Given this list of marker genes SYT2 (NCBI Gene Id 6858), MECOM, CEP57, NELFA, RPS26, TTC7A, FRAS1, MYOD1, RPS17, NDN, MAP3K20, ADA, DNA2, EPB41, GTF2IRD1, MT-ND1, MAX, EIF4H, CNTNAP1, PIGL, TBCK, SZT2, NPC1, TREM2, PLPBP, TRIP13, KIF26A, TIMMDC1, TLK2, PTH1R, EXTL3, DPF2, UNC45B, TCF4 (transcription factor 4), SCN4A, KLHL40, GABRG2, TRIP11, BMPER, YWHAG, SON, SMN1, B3GLCT, PEX2, CYFIP2 (cytoplasmic FMR1 interacting protein 2), MYH3, GTF2I, GAA, ATP1A3, PIGA, RIPK4, DHDDS, SOS2, RPS24, KRAS, ABCB4, CACNA2D1 (NCBI Gene Id 781), HBA2, TAF6, FLT4, RPL31, VCP (NCBI Gene Id 94731), SMC1A, PIGY (NCBI Gene Id 84992), MRAS, CASP10, BSND, MAPT, LZTR1, RFC2, H19, EFNB1, NAA10, NDUFB9, HOXD13, RAI1, CARS2, MDFIC, TRPV4, HLCS, ATP6V1B2, PEX26, FOXC2, KBTBD13, PARS2, UQCRFS1, SCYL2, GATA1, GNB2, VPS35L, PAX7, SLC25A26, PLD1, MEGF10, MTM1, KCNC2, ZSWIM6, NCF1, RAD21, NFASC, RRAS2, PRUNE1, PWAR1, GOSR2, DPYSL5, FAT4, COL6A1, RPL26, CAMK2B, RPS29, CLPB, RYR1, CRB2, NEK9, ARSL, SPTA1, SLC5A7, RRAS, SLC17A5, NDUFAF5, SLC2A1, SCN5A, DHPS, CRPPA, NDUFAF2, TMCO1, BUB1B, GATB, DEAF1, ITPR1, NDUFAF1, FLG, NTRK2, SCN3A, PIGV, KCNQ5, SPRED2, KMT2D, PAK2, NDUFV2, HCN1, NDUFS2, HACD1, MMACHC, PTRH2, LAMA5, DNM2, DNMT3A, PGAP2, NDUFS7, CNTN1, NEU1, NSD2, FANCF, IL7R, LBR, RHD, KANSL1, SLC3A1, ATN1 (atrophin 1), ATP8B1, NDUFV1 (NCBI Gene Id 4723), MRPS16, GUSB, SLC26A2, FZR1, EBF3, HEATR3 (HEAT repeat containing 3), TMEM270, PMM2, LIMK1, RAPSN, FASLG, DOHH, LGI4, GRIP1, RET, POLR2A, ZNF699, NDUFA10, SLC13A5, PGAP3, MRPS22, KLF1, ADGRG6, STX1A, DMPK, NPC2, MCM10, ASCL1, RPS10, MYT1L, CLIP2, SYNJ1, GABBR2, RPL15, BAZ1B, RASA1, FXR1, PLOD1, PREPL, GBE1, RPS19, SNUPN, MAGEL2, VAMP1, FGFR3, CHAT, CDAN1, CPSF3, MTMR14, NDUFS8 (NCBI Gene Id 4728), CLCN3, FIG4, RIT1, SLC18A3 (solute carrier family 18 member A3), QRSL1, TMEM106B, CTCF, DOCK11, FKBP14, ODC1, CCDC22, WNT7A, ADARB1, COG8, TBC1D24, BRD4, PIGO, GYPC, LMNA, NSD1, RAF1, HADHA, EXOSC9, MKRN3, CDK19, FOXRED1, PIGS, GABRB2, UROD, ZBTB18, SCN8A, BNC2, DYNC2I2, ZIC3, ADA2, NUP188, MYH7, CHRNA1, NUBPL, PWRN1, CALCRL, GRN, TMEM126B, IGHMBP2, FBXO28, GATA6, H4C3, RYR3, WNT3, PPM1B, PI4KA, LARS2, RPS20, NDUFB3, MYL2, NDUFAF4, CCDC47, MAP3K7, RRAGC, HDAC8, PHOX2B, COL25A1, CCBE1 (collagen and calcium binding EGF domains 1), DOK7, DALRD3, VAC14, NDUFB11, ADCY6, DPAGT1 (NCBI Gene Id 1799), PEX14, RPL5 (NCBI Gene Id 90045), SNAP25, KIF5C (kinesin family member 5C), TRAK1, MYO9A, NIPBL (NIPBL cohesin loading factor), VPS13B, GBA1, SLC1A2, MYL9 (myosin light chain 9), SNORD115-1, DNM1, NEXMIF, COL1A2, ALPK3, DYNC2H1 (dynein cytoplasmic 2 heavy chain 1), WT1, EMC10, TPM3, GATC, FGF13 (fibroblast growth factor 13), MYL1, DPH5, MUSK, CAMKMT, FBXL4, SCN1A, DHCR7, NDUFA1, ERGIC1, CACNA1B, ELN, SELENON, MT-ND2, TOR1A, SLC25A19, EIF5A, RPS27, ZBTB42, GLE1, UBA5, SCARF2, SPECC1L, RAG2, LMOD3, RAB34, AP3B2, IL2RG, RNU4ATAC, SQSTM1, NAA20, RPL18, COL12A1, HPS6, SYNE1, ERCC5, IFT80, SHQ1 (SHQ1, H/ACA ribonucleoprotein assembly factor), RPL11, LIG4, RPL27, TBL2, DOCK6, IL2RB, FLNB, CRLS1, CLXN, SLC35D1 (solute carrier family 35 member D1), FKBP6, SPEN (spen family transcriptional repressor), FAS (NCBI Gene Id 355), OCA2, COX15, MYMK, NEK1, ADAMTS3, NPAP1, CTSA, AGRN, PACS2, KLHL41, RAP1B, SLC31A1 (NCBI Gene Id 1317), ERBB3, PIEZO1, WDR62, ASXL2, ATP1A2, MYL11, STS, WWOX, PEX5 (peroxisomal biogenesis factor 5), THSD1, RAG1, IGF2, CHRND, SLC27A4, CACNA1A, FANCB, USP18, RPL35, SPTB, KIF21A, FH, HSPG2, RAC1, CPLX1, MKS1, IFT56, BUB3, ASNS, BICD2, FOXG1, TALDO1, GLB1, CNKSR2, IL1RN, MCTP2, AHCY, USP7, GPC6 (NCBI Gene Id 10082), CCDC174 (NCBI Gene Id 51244), WNT4, IPO8, DNM1L, PKLR, PEX12, HBA1, COL13A1, GTF2IRD2, GFPT1, NDUFAF3, GGPS1, AP1S2, RPL9, TRAF7, PEX10, RPS15A, CHMP2B, GLRB, ASCC1, NECAP1, COL6A3, EPHB4, RMRP (NCBI Gene Id 6023), ATP6V1A, PEX1, RPL8, CHRNG, RPS7, TRIP4, NALCN, UBA1, CTBP1, COL2A1, KIAA0586 (KIAA0586), TUBA1A, SLC35A2, PHGDH, ATAD3A, POR, KCNB1, STAG1, DNAJC30, SLC30A9, SOX10, AARS1, ALG14, EEF1A2, SLC25A1, COX11, ESAM, MT-ND3, PIGG, NDUFS1, KCNA2, NDUFS3, RASA2, ABCD4, EBP, NDUFB10, FGF12, TNNC2, FOXF1, SYNGAP1, AFF2, B9D1, LETM1, FGFRL1, TWIST2, OSTM1, QRICH1, RPL35A, GABRA5, PSAT1, SOX18, STX5, NRAS, RPS28, COL1A1, COL11A1, KIF20A, NEB, NDUFS4 (NADH:ubiquinone oxidoreductase subunit S4), PSEN1, ACTA1, TAPT1, METTL27, PIK3CA, BIN1, HRAS, CELF2, NSF, PEX13, CLTC, CSGALNACT1, DDX6, GABRA2, SLC6A9, TRAIP, MGAT2, DYNC2I1, CACNA1C, ASAH1, CHD7, ALG8, SMC3, COL6A2, MYPN, LYN, VPS37D, TRIM37, ALDH7A1, HERC2, HNRNPK, WDR35 (NCBI Gene Id 57539), NUS1 (NCBI Gene Id 116150), SNRPN, GPKOW, LRPPRC (leucine rich pentatricopeptide repeat containing), ACTL6B, PPP3CA, SLC16A2, ZC4H2, ENPP1, PIGN, IQSEC2, GRIN2D, CHRNE (NCBI Gene Id 83405), WASHC5, PEX19, UROS, FILIP1, SNORD116-1, CHUK, AGGF1, NDUFA11 (NCBI Gene Id 126328), PEX16, ABCC6, SLC38A3, RNU4-2, HSD17B4, PIGW, CBL, GLDN (NCBI Gene Id 342035), MYF6, PEX11B, CAPRIN1 (cell cycle associated protein 1), MYCN, IKZF1, PEX6, BUD23, ZMPSTE24 (NCBI Gene Id 10269), PACS1, PTPN11, BUB1, NR1H4, TGM1 (transglutaminase 1), MPZ, TPM2, TSFM, NUP88, ALG1, GMPPB, TXNDC15, CRELD1, DCLRE1C, NDUFA6, NDUFAF8, CDC42BPB, ITGA7, TSR2, SOS1 (NCBI Gene Id 7838), FLII, ALG9, NDUFS6, PEX3, here is a description of the gene set: Structural or functional abnormalities of the fetus. Note that this section comprises terms that describe abnormalities that are specific to the fetus or differ from the corresponding general terms. A term from anywhere in the Human Phenotype Ontology can be applied to a fetus if appropriate. studied in species Homo sapiens Human Gene Set: HP_FETAL_ANOMALY Fetal anomaly